Given this list of marker genes GLRA1, VPS35, GCH1, SPR, PTS, SCN2A, TSPOAP1, GABRA1, SLC1A2, RYR1 (NCBI Gene Id 906), PPP3CA, DNM1, ASPA, COX11, RNU4ATAC, LRRK2, COASY, UQCRC1, MT-TT, LSM11, PACS2, ABCA12, UBTF, GALC, ATL1, GBA1, KCNA4, FZR1, GAMT, DNAJC13, ADH1C (alcohol dehydrogenase 1C (class I), gamma polypeptide), RNASEH2B, NUP62, GPRC5B, CLTC, IFIH1, COQ2, SCN8A, WWOX, SMPD1, PDE8B, STUB1, ATXN8OS, RAB39B, ITM2B, OGDH, GLB1, WDR45, EEF1A2, SNCA, ACTA1, SLC30A10, UCHL1, SYNJ1, SAMHD1, TUBB4A, CHCHD2, ATAD1, PDGFRB, RANBP2, PCDH19, MICU1, RNASEH2A, MYO5A, SCN1B, CDK19, PTCD3 (NCBI Gene Id 55037), PRNP, CP, SLC1A3, MECP2, ARX, ATXN2, HTRA1, POLG2, HLA-DQB1, RNASEH2C, SLC6A5, TREX1, AQP4, MAPT, FRRS1L, KCNA2, NUP54 (nucleoporin 54), YWHAG, SLC2A3, LNPK, ATP7B, GABRA2, CACNA1A, ATP13A2, JAM2, GABBR2, TWNK, REEP2, ATP1A3, POLG, DNAJC6, FOXRED1 (NCBI Gene Id 55572), MECR, RNU7-1, CRYAB, SCN9A, GFAP, AP3B2, BRAT1, ACTL6B, PARS2, PODXL, EXTL3, GJC2, PDGFB, FGFR1, PLAA, IMPDH2, CELF2, SYNGAP1, PIGA, CACNA2D1, ATXN3, FBXO28, ENSG00000288330, FBXO7, PTPA, LDHA, FTL, ATP6AP2, HCN1, DDHD2, TAF1, ATP6V1A, NAXE, CNKSR2, KCND3, VPS13C, SLC20A2, NTRK2, CACNA1B, GPHN, DALRD3, PRRT2, CASK, CHMP2B, CHKA, FOXG1, KCNN2, LOXL1 (lysyl oxidase like 1), GABRA5, NR4A2, NOTCH2NLC, KIF11, FGF12, SLC25A4, SNCAIP, SLC13A5, ATP1A2, PTRHD1, PRKN (NCBI Gene Id 8004), MT-ATP6, KRAS, NDUFAF6, GLRB, GCDH (glutaryl-CoA dehydrogenase), KCNB1, TK2, GIGYF2, EIF2AK2, KCNC2, SLC6A3, ARSA, PLA2G6, DHCR24, PEX16, PARK7, PSAP, DCTN1, GRIN2D, SEMA6B, GABRG2, SLC38A3, AFG3L2, CSF1R, OPA3, TBP, PNKD, DHDDS, TRAK1, CYFIP2, HTT (huntingtin), SZT2, DDHD1, EIF4G1, TH, TMEM240, SCN1A, JPH3, SIL1, PINK1, SCN3A, FMR1, HTRA2, AARS1 (alanyl-tRNA synthetase 1, NCBI Gene Id 16), PANK2, UBA5, ADAR, DAB1, NECAP1, PRKCG, NUS1, GABRB2, MME (NCBI Gene Id 4311), CTSD, SLC19A3 (solute carrier family 19 member 3), RRM2B, here is a description of the gene set: studied in species Homo sapiens Continuous involuntary sustained muscle contraction. When an affected muscle is passively stretched, the degree of resistance remains constant regardless of the rate at which the muscle is stretched. This feature helps to distinguish rigidity from muscle spasticity. Rigidity Human Gene Set: HP_RIGIDITY